Given this list of marker genes FAS, LGALS3BP, XAF1, BATF2, DHX58, IL18BP, BTG1, C1R, IL15RA, PLSCR1, UPP1 (uridine phosphorylase 1), NFKBIA, CMPK2, STAT3, NFKB1, STAT2, SOCS1 (NCBI Gene Id 8651), IRF2, OGFR, RIPK1, OASL, SELP (selectin P), C1S, BPGM, BANK1, TDRD7, EIF2AK2, SRI, NLRC5, LYSMD2, SOCS3, SLC25A28, XCL1, STAT4, ADAR, LY6E, LATS2, CXCL11, RNF213 (NCBI Gene Id 79398), B2M, TOR1B, TNFAIP2, CD86, PML, FCGR1A, RBCK1, IFI27, P2RY14, CASP4, PTGS2, PSME1, PARP14, IRF1, TAP1, IL6, AUTS2, ARL4A, IFI35, ISG15, IL7, SPPL2A, CFB, TRIM21, CCL2, ST3GAL5, RAPGEF6, DDX60, LCP2, CIITA, OAS3, TMT1B, PSMA3, RSAD2, IFIT3, VAMP5, SERPING1, CCL5, IFI44L, PLA2G4A, OAS2, CCL7, HLA-DRB1, CD40, CASP8 (NCBI Gene Id 841), IRF7, PSMA2, GPR18, VAMP8, PSME2, IFI44, PSMB2, NOD1, IFIT1, PELI1, IFIH1, IFITM3, ITGB7, MX2, APOL6, IRF8, RIGI, WARS1, IL15, FPR1 (NCBI Gene Id 2357), HLA-DMA, MT2A, HLA-G, ST8SIA4, PDE4B, KLRK1, MX1, UBE2L6, NUP93, CSF2RB, ARID5B, PSMB9, CD38, RNF31, MYD88, CD74, SOD2, BST2, TNFSF10, PTPN1, PNP, TNFAIP3, CASP7, IL2RB, EPSTI1, PTPN6, MARCHF1, CASP3, CXCL10, ICAM1, EIF4E3, ISOC1, ZNFX1, IL10RA (interleukin 10 receptor subunit alpha), RIPK2, CMKLR1, IFNAR2, CXCL9, PTPN2, TRIM14, VCAM1, HELZ2, PFKP, CD274, HERC6, GBP4, MVP (major vault protein), TAPBP, GZMA, CASP1, HLA-A, ZBP1, PNPT1, GBP6, TRIM25, STAT1, SP110, PSMB8, NAMPT, HIF1A (NCBI Gene Id 3091), TXNIP, TRAFD1, USP18, TRIM26, NMI, LAP3, IRF9, IFIT2, TNFAIP6, SLAMF7, SAMHD1, MTHFD2, HLA-DQA1, HLA-B, CD69, CFH, JAK2 (NCBI Gene Id 3717), IDO1, SSPN, CMTR1, SECTM1, SAMD9L, IFI30, PIM1, FGL2 (fibrinogen like 2), CDKN1A, ISG20, NCOA3, IRF5, IRF4, IFITM2, PARP12, IL4R, RTP4, PSMB10, GCH1, here is a description of the gene set: from publication Liberzon A, Birger C, Thorvaldsdóttir H, Ghandi M, Mesirov JP, Tamayo P (PMID 26771021) Genes up-regulated in response to IFNG. species: Homo sapiens Human Gene Set: HALLMARK_INTERFERON_GAMMA_RESPONSE